Given this list of marker genes CTXN1, C1QL4, DBNDD1, PALS2, HKDC1, ANKRD1, CLDN9, PTPN14, LOXL4, ABHD3, VTCN1, KRT23, OXTR, CDH6, LURAP1L, CSPP1, DEFB1, MLH3, GUSBP14, WNK2, KCNF1, VEPH1, SMYD2, GMNN, KANSL1L, TMEM156, GAREM1, H4C8, PSPH, ITIH5, SCTR, LPGAT1, RGS4, FGFR2, GOLGA7B, HNF1B, PTHLH (parathyroid hormone like hormone), PAQR5, DCDC2, UBD, TNFRSF12A, NUAK2, CXCL6, PATZ1, NME5, GGT6, PGBD5, SLC4A3, H1-2, SLC5A9, PIEZO2, PKHD1, RGS14, CRYM, ATP1A1, SPP1, ZDHHC1, GAL3ST1, SYT12 (synaptotagmin 12), MTCL1, CRYBB2, MCCC2, VN1R1, here is a description of the gene set: Human Gene Set: ANDERSEN_CHOLANGIOCARCINOMA_CLASS1 In approximately 70% of patients with hepatocellular carcinoma (HCC) treated by resection or ablation, disease recurs within 5 years. Although gene expression signatures have been associated with outcome, there is no method to predict recurrence based on combined clinical, pathology, and genomic data (from tumor and cirrhotic tissue). We evaluated gene expression signatures associated with outcome in a large cohort of patients with early stage (Barcelona-Clinic Liver Cancer 0/A), single-nodule HCC and heterogeneity of signatures within tumor tissues. studied in species Homo sapiens Genes overexpressed in cholangiocarcinoma class 1 associated with good prognosis from publication Villanueva A, Hoshida Y, Battiston C, Tovar V, Sia D, Alsinet C, Cornella H, Liberzon A, Kobayashi M, Kumada H, Thung SN, Bruix J, Newell P, April C, Fan JB, Roayaie S, Mazzaferro V, Schwartz ME, Llovet JM (PMID 21320499)